Given this list of marker genes PPP3CA, SOX9 (NCBI Gene Id 6662), PAX2, WNT4, FOXD1, SOX8 (SRY-box transcription factor 8), RET, AGTR2, MYC, NOG, here is a description of the gene set: Any process that increases the rate, frequency or extent of kidney development. Kidney development is the process whose specific outcome is the progression of the kidney over time, from its formation to the mature structure. The kidney is an organ that filters the blood and excretes the end products of body metabolism in the form of urine. species: Homo sapiens Human Gene Set: GOBP_POSITIVE_REGULATION_OF_KIDNEY_DEVELOPMENT